Given this list of marker genes Pcdhga10, Slc6a15, Rgn, Pcdhga1, Unc5d, Fnbp4, Pcdhga3, Pcdhga9, Pcdhga5, Cd86, Mapk1, Eps8, Tfam, Zfand6, Pcdhgb8, Pcdhgb7, Rusf1, Pde3b, Mbnl2, Armt1, Cradd, Pcdhga8, Pcsk1n, Prss23, Nr4a3, Ids, Pcdhga11, Lrrtm4, Pcdhga7, Pcdhgc3, Mbtd1, Plekhb2, Hacd4, Tfdp2, Dmtf1l, Sec13, Pcdhga12, Otop1, Pcdhga2, Agbl3, Aebp2, Hipk3 (NCBI Gene Id 15259), Marchf8, Vps25, Dpysl5, Lmx1a (NCBI Gene Id 13485), Eloc, Scrg1, Max, Bri3bp (NCBI Gene Id 76809), Med9, here is a description of the gene set: from publication Chen Y, Wang X (PMID 31504780) Genes predicted to be targets of miRBase v22 microRNA mmu_miR_3088_5p in miRDB v6.0 with MirTarget v4 prediction scores > 80 (high confidence targets). species: Mus musculus Mouse Gene Set: MIR_3088_5P